The following is a description of a gene set: from publication Fontaine JF, Mirebeau-Prunier D, Franc B, Triau S, Rodien P, Houlgatte R, Malthièry Y, Savagner F (PMID 17968324) Genes up-regulated in thyroid tumors of uncertain malignancy (T-UM) compared to other thyroid tumors. species: Homo sapiens Human Gene Set: FONTAINE_THYROID_TUMOR_UNCERTAIN_MALIGNANCY_UP Conventional histology failed to classify part of non-medullary thyroid lesions as either benign or malignant. The group of tumours of uncertain malignancy (T-UM) concerns either atypical follicular adenomas or the recently called 'tumours of uncertain malignant potential'. To refine this classification we analysed microarray data from 93 follicular thyroid tumours: 10 T-UM, 3 follicular carcinomas, 13 papillary thyroid carcinomas and 67 follicular adenomas, compared to 73 control thyroid tissue samples. The diagnosis potential of 16 selected genes was validated by real-time quantitative RT-PCR on 6 additional T-UM. The gene expression profiles in several groups were examined with reference to the mutational status of the RET/PTC, BRAF and RAS genes. A pathological score (histological and immunohistochemical) was estimate for each of the T-UM involved in the study. The correlation between the T-UM gene profiles and the pathological score allowed a separation of the samples in two groups of benign or malignant tumours. Our analysis confirms the heterogeneity of T-UM and highlighted the molecular similarities between some cases and true carcinomas. We demonstrated the ability of few marker genes to serve as diagnosis tools and the need of a T-UM pathological scoring., and this is the list of marker genes: VEGFC, SNCB, CA11, OAZ2, CLDN7, PBXIP1, TSHR, GRB10 (NCBI Gene Id 9769), PTK2, CCL1, UGGT1, PDCD4, SATB1, CTNNA1, TMEM125, MESD, TENM1, PSAT1, BCL2L11, CAPN3, AQP4, NR2F2, ARMCX4, SPATA3-AS1, ARIH2, KPNA2, KCNK5, SNRPG, ZMYM5, CHRAC1, TESC, FLT1, CD63, CITED1, FBXL16, NIPAL3, IGF2BP2, CD4